Given this list of marker genes GABRA3, GABRA1, GABRA6, GABRB2, GABRB1, GABRQ, GABRA5, GABRG1, GABRB3 (NCBI Gene Id 2562), GABRD, GABRG3, GABRA4, GABRR1, GABRP, GABRA2, GABRR2, GABRR3, GABRG2, GABRE, here is a description of the gene set: Human Gene Set: GOMF_GABA_A_RECEPTOR_ACTIVITY studied in species Homo sapiens Combining with the amino acid gamma-aminobutyric acid (GABA, 4-aminobutyrate) to initiate a change in cell activity. GABA-A receptors function as chloride channels.